Given this list of marker genes RBPJ, HES1, HES5, ILK, KDR, ZNF423, SCUBE3, NOTCH2, NUMA1, MIR140, NGLY1, MIR20A, ARK2C, CCN1, GATA4, SMAD5-AS1, TBX20, KCP, MSX1, ACVRL1 (activin A receptor like type 1), CDH5, NEO1, GDF2, PELO, SOX11, GPC3, BMP4, FOXD1, NOTCH1, SMAD2, UBE2O, SULF1, GDF5, CRB2, FBXL15, TWSG1, ENG, FKBP8, MSX2, ELAPOR2 (NCBI Gene Id 222223), here is a description of the gene set: Any process that activates or increases the frequency, rate or extent of BMP signaling pathway activity. Human Gene Set: GOBP_POSITIVE_REGULATION_OF_BMP_SIGNALING_PATHWAY studied in species Homo sapiens